Given this list of marker genes LRP5, FZD4, NTN4, NDP, FER, here is a description of the gene set: Any process that mediates the transfer of information between the extracellular matrix and a cell. studied in species Homo sapiens Human Gene Set: GOBP_EXTRACELLULAR_MATRIX_CELL_SIGNALING